Given this list of marker genes Ormdl3, Rgp1, Cpox, Wasf2 (WASP family, member 2), Slf2, Trpm1, Ncoa2, Scx, Krt80, Lrch3, Mtch2, Parvb, here is a description of the gene set: Mouse Gene Set: MIR_7672_3P from publication Chen Y, Wang X (PMID 31504780) species: Mus musculus Genes predicted to be targets of miRBase v22 microRNA mmu_miR_7672_3p in miRDB v6.0 with MirTarget v4 prediction scores > 80 (high confidence targets).